Given this list of marker genes Spry1, Ankfn1, Rhog, Fscn3, Rac1, Kif26b, Brsk1, Rhobtb1, Stk11, Foxj1, Apc, Fermt1, Spag6l, Spdl1 (NCBI Gene Id 76404), Ubxn2b, Cep290, Gpsm2, Myo18a, Lrrc7, Alpk2, Wee1 (NCBI Gene Id 22390), Brsk2, Mos, Dynlt1b, Pafah1b1, Llgl2, Dlg5, Rab10, Gja1, Vangl2, Rab11fip2, Pard3, Myo9a, Nsfl1c, Rhoq, Pkd1, Plk1, Prkcz, Parva, Numa1, Rpgrip1l, Exoc4, Cfl1, Fbf1, Rac2, Fbxw11, Diaph3 (NCBI Gene Id 80466), Flot2, Cyp26b1, Crb2, Kcnj8, Scrib, Wnt5a, Amotl1, Wnt11, Rictor, Ska2, Dock8, Mad2l1, Spag5, Dlg3, Fat1, Tcirg1, Ooep, Abl2, Pard6g, Kif20b, Macf1, Tsc2, Fscn1, Ilk, Coro7, Map2, Wdpcp, Llgl1, Ehbp1l1, Shh, Phldb2, Carmil1, Gbf1, Nckap1, Lims1, Cdc42, Ska1, Ccl21f, Ephb1, Pdlim1, Inppl1, Crk, Ccl19-ps5, Ccl21a, Pard6b, Parvb, Arf6, Kank1, Cyth3, Dlg2 (discs large MAGUK scaffold protein 2), Misp, Pkhd1, Zw10, Hdac3, Ift20, Frmd4a, Pard6a, Rhoj, Igf1r, Dctn1, Hey1, Ccr7, Msn, Spint2, Fscn2, Sapcd2, Actb, Mcph1, Jam3, Fez1, Kcnq2, Tek, Krit1, Frmd4b, Map4, Clasp2, Abl1, Tcf15, Shtn1, Ccdc66, Aqp1, Bccip, Ckap5, Actr3, Ccl19-ps6, Lmna (lamin A), Plekhg3, Ccl21d, Ust, Crb1, Nde1, Cdh5, Foxf1, Igf1, Pals1, Arhgap35, Camsap3 (NCBI Gene Id 69697), Hes1, Itgb1, Arfgef1 (NCBI Gene Id 226334), BC034090, Ank3, Rufy3 (RUN and FYVE domain containing 3), Rac3, Fgf13, Spry2, Pdcd6ip, Rack1, Kat5, Nphp3, Kif2c, Rhobtb2, Sh3bp1 (SH3-domain binding protein 1), Mark2, Ttc8, Myh9, Dock2, Rhou, Crtam, Prkci, Cyrib, Ccl21e (NCBI Gene Id 100504239), Cyth1, Actr2, Mapre1, Ccl19-ps3, Nckap1l, Prickle2, Ccl19-ps1, Hes5, Carmil2 (NCBI Gene Id 234695), Ccl19-ps4, Sipa1l3, Stk25, Myo9b, Arf4, Ccl19, Gsk3b, Enkd1, Ska3, Clasp1, Sdccag8, Mtcl1, Cd3g, Golph3, Atn1, Wdr1, Crkl, Cdx2, Wnt7a, Cdk5rap2, Dst, Ndc80, Rhov (ras homolog family member V), Patj, Nherf1, Prickle1, Pax6 (NCBI Gene Id 18508), Ccl21b, Crb3 (NCBI Gene Id 224912), Dlg1, Wnt7b, Amot, Htt, Lama1, Ezr, Gsn, Lhx2, Syne4, Rap1b, Arpc5, Gpsm1, Parvg, Pard3b, Ptk7, Fam89b, Ophn1, Nek3, Arhgef2, Amotl2, Rhoa, Snap91, Cenpa, Fgf10, Ctnna1, Ift80, Slc9a6, Map1b, Traf3ip2, Kif3a, Ripor2, Pak1, Ndel1, Dock7, Ccdc85c, Gata3, here is a description of the gene set: Any cellular process that results in the specification, formation or maintenance of anisotropic intracellular organization or cell growth patterns. Mouse Gene Set: GOBP_ESTABLISHMENT_OR_MAINTENANCE_OF_CELL_POLARITY studied in species Mus musculus